The following is a description of a gene set: species: Homo sapiens Human Gene Set: GOBP_NEGATIVE_REGULATION_OF_T_CELL_RECEPTOR_SIGNALING_PATHWAY Any process that stops, prevents, or reduces the frequency, rate or extent of signaling pathways initiated by the cross-linking of an antigen receptor on a T cell., and this is the list of marker genes: PAWR, CD160, THY1, DUSP3 (dual specificity phosphatase 3), CBLB, PTPN6, LGALS3, PTPRJ, BTN2A2, CEACAM1, NCK1, SLA2, EZR, BTRC, ELF1, ITPRIPL1, CSK, SH2D1A, DUSP22, PTPN22, PRNP, LAPTM5, DGKZ, PTPN2, PHPT1, BTNL2, PVRIG, GBP1, UBASH3A, LILRB4